The following is a description of a gene set: Any structural anomaly of the conus terminalis, which is the distal bulbous part of the spinal cord at the location where the spinal cord tapers and ends (usually between the L1 and L2 lumbar vertebrae). Human Gene Set: HP_ABNORMAL_CONUS_TERMINALIS_MORPHOLOGY studied in species Homo sapiens Abnormal conus terminalis morphology, and this is the list of marker genes: ZMYM2, VANGL1, EXT1, PIK3CA, CPLX1, TRAF7, RASA1, KDM1A, NOTCH3, PRMT7, TRAPPC14, NFIA, CREBBP, MNX1, NELFA, CTBP1, SCAF4, EXT2, NSD2, SUPT16H, SALL1, LETM1, ARPC4, HAAO, DARS1, CTNNB1, NCAPG2, HNRNPH1, PIGG, SPTSSA (NCBI Gene Id 171546), FGFRL1, RAD51